The following is a description of a gene set: Human Gene Set: GOBP_CELLULAR_EXTRAVASATION The migration of a leukocyte from the blood vessels into the surrounding tissue. species: Homo sapiens, and this is the list of marker genes: ITGB7, CCL28, GOLPH3, TNF, LYVE1, ELANE, PTGER4, CCR2, SELL, PODXL2, FADD, CRK, EXT1, PLVAP, CCL21, GCNT1, CD99L2, ITGB2, MADCAM1, SELE, ITGAL, SELP, MDK, BST1 (NCBI Gene Id 683), PIK3CG, CXCL12, SIRPA, PIK3CD, TRIM55, SELPLG, CCL2, CD99, PLCB1, ST3GAL4 (NCBI Gene Id 80040), ITGB1, CRKL, AZU1, ADAM8, F11R, CX3CR1, JAM2 (NCBI Gene Id 58494), LEP, ITGA4, FER, CHST4, XG, CHST2, SPN, ICAM1, ITGA1 (NCBI Gene Id 3672), PRTN3, PECAM1, ADD2, RIPOR2, FUT7, AGER, JAM3, MIR146A, CX3CL1, JAML, CD47, IL1R1, RIPK3, IL27RA, MED23, FUT9, CCL25, BCR, THY1 (Thy-1 cell surface antigen), PDGFD, ROCK1, VCAM1, FUT4, CD177